The following is a description of a gene set: studied in species Homo sapiens Proximal mislocalization of the thumb. Proximal placement of thumb Human Gene Set: HP_PROXIMAL_PLACEMENT_OF_THUMB, and this is the list of marker genes: NIPBL, RRAS2, LONP1, CTCF, TP63, EIF4A3, FRA10AC1, FLNA, RAD51C, DHCR7, SHMT2, BAP1, ESCO2, SMC3, BRCA1, SMC1A, MGAT2, NKX3-2, ZNF462, ANKRD11, RECQL, TAF6, RAD21, SIN3A, ALG12, EFTUD2, NOG, ZIC3, PTRH2, ERI1 (NCBI Gene Id 90459), WDR26, KCNH1, SLC26A2, HDAC8, ZC4H2 (zinc finger C4H2-type containing), FANCB, TFAP2A, GATA4, CDC42, BMP4, CRIPT, HOXA13, BRD4, B3GLCT, TBX5